Given this list of marker genes Snw1, Smad3, Smad5, Smad9, Smad2, Smad1, Smad7, Smad6, Hmga2, Smad4, here is a description of the gene set: species: Mus musculus Mouse Gene Set: GOCC_SMAD_PROTEIN_COMPLEX A protein complex that consists of only SMAD proteins; may be homomeric or heteromeric. Heteromeric complexes act as transcription factors while homomeric complexes exist but are transcriptionally inactive. Hetero- versus homotrimerization is largely enthalpy driven.